Given this list of marker genes ENO3, PCDH7, TRPC2, MPV17L, TRIM33, CAP2, EIF2S2, SPAG1, NXN, ARL4D, IVL, ACYP1, FAM120C, CALCRL, PPM1H, MGAM, LRRIQ3, MCU, PDE1C, CERS5, ELMOD2, PHF21B, SGSM2, RPL29, SERPINI1, CDK8, TSPOAP1, KRT80, PLA2G2E, SIGIRR, LRRC42, FAM118B, SLC35F2, RPS11, TNS4, MGMT, PURG, IQCG, TMEM33, RASAL2, HTR2B, SERPINB12, DCAF8, PYROXD2, FGFRL1, GPAT2, ZHX1, ABCA7, C2CD2L, LPGAT1, TCP11L2, LECT2, PLA2G5, DGKI, ZDHHC20, KIF9, PBX4 (PBX homeobox 4), GPM6B, FDX1, HOXA5, FOLR1, CLSTN3, GIMAP6, NCAM2, KCNH1, GABARAP, FYTTD1, FBXL17, GTSF1, KIFC2, GLRA2, TNKS1BP1, TUSC3, UNC119B, PSMA8, CNTNAP1, PRDM5, C1GALT1, TCHP, SEZ6L2, TNPO1, MEGF8, EPHB2, ACY3, ARL5B, SLC38A2, CCDC54, SLC25A42, RPL39, GCLC, ELOVL6, EMP3, ZKSCAN3, CSN1S2AP, B4GALNT2, SCRN2, IL2RA, SMOC1, ADAM19, MEGF10, KYAT1 (NCBI Gene Id 883), HSF4, AGPAT5, NDFIP1, SERINC5, ZFTRAF1, CORO2B, NCOA1, LLGL2, HOXA7, NEU1, MCOLN3, TMEM62, KIF4B, TMEM8B, BAMBI, TMEM9B, EEF1A2, MT-ND3, AMOTL1, MIR200B, NLRP10, here is a description of the gene set: Cells from four develppmental stages were purified by FACS from human bone marrow samples from publication Hoffmann R, Lottaz C, Kühne T, Rolink A, Melchers F (PMID 17890238) species: Homo sapiens Human Gene Set: GSE4590_PRE_BCELL_VS_SMALL_PRE_BCELL_DN Genes down-regulated during B lymphocyte differentiation: pre-B I versus small pre-B II.